Given this list of marker genes TMEM147, GAK, VAPB, RAB3GAP1, MIA3, TRDN, WNK1, LMAN1, IER3IP1, RTN1, CACNA1S, DNM1L, TOR1AIP2, TMED2, STX18, RAB10, RAB3GAP2, SEC16A, SGTA, UBL4A, TMEM38B, ZFYVE27, TLE6, CASQ1, GET1, ATL2, TMEM33 (transmembrane protein 33), CRYZL2P-SEC16B, RTN3, NOMO3, GET4, SPTSSB, SEC16B, NCLN, EMC4, RAB5IF, LRRK2, EMC9, TMCC1, TMCO1, TRAM1, LPCAT3, SEC61A1, RTN4, EMC10, REEP1, GET3, EMC3, NOMO1, CAMLG, TMEM38A, TRAM1L1, VCPIP1, ZBED3, TOR1B, NOMO2, SHTN1, EMC7, RETREG3, PEX5, EMC1, BAG6, ESYT1, JAGN1, ATL3, EMC8, CAV2, SEC31A, REEP2, CERT1, REEP4, EMC6, ESYT3, SMPD4, TRAM2, ARL6IP1, STEEP1, POLR2M, RNF112, TMEM170A, DMTN, ATL1, REEP3, UMOD, BNIP1, RTN2, MAPK15, DOP1B, CCDC47, RETREG2, ESYT2, EMC2, REEP5, EIF2AK3, USE1, VAPA, SEC31B, RAB18, MMGT1, LNPK, REEP6, WDR83OS, GRAMD2A, RETREG1, here is a description of the gene set: A process that is carried out at the cellular level which results in the assembly, arrangement of constituent parts, or disassembly of the endoplasmic reticulum. Human Gene Set: GOBP_ENDOPLASMIC_RETICULUM_ORGANIZATION species: Homo sapiens